The following is a description of a gene set: Mouse Gene Set: GOMF_DICARBOXYLIC_ACID_TRANSMEMBRANE_TRANSPORTER_ACTIVITY Enables the transfer of dicarboxylic acids from one side of a membrane to the other. A dicarboxylic acid is an organic acid with two COOH groups. studied in species Mus musculus, and this is the list of marker genes: Slc26a5, Slc1a4, Slc25a18, Slc1a1, Slc25a12 (NCBI Gene Id 99450), Slc26a8, Slc26a2, Slc22a6, Slc25a10, Abcc2, Slc19a1, Slc13a5, Slc46a1, Slc25a22, Slc26a3, Slc1a5 (solute carrier family 1 (neutral amino acid transporter), member 5), Slc16a1, Slc26a6, Slc26a4, Slc25a13, Slc26a9, Ucp2, Slc26a1, Slc13a2, Slc1a6, Slc22a7, Slc25a11, Slc25a21, Slc26a7, Slc13a3, Slc26a10